The following is a description of a gene set: studied in species Homo sapiens An increased susceptibility to lower respiratory tract infections as manifested by a history of recurrent lower respiratory tract infections. Human Gene Set: HP_RECURRENT_LOWER_RESPIRATORY_TRACT_INFECTIONS Recurrent lower respiratory tract infections, and this is the list of marker genes: SLC19A1, SLC11A1, STIM1, EXTL3, IRF1, FCN3, HYOU1, MAP3K14, MALT1 (MALT1 paracaspase), PRKDC, TNFSF12, CYBC1, DOCK11, G6PC3, NCF2, SIAH1, COL6A1, NME5, NFE2L2, ZNF668, CTCF, FMO3, PKHD1, CD40LG, DNAAF4, TCF3, RFT1, COLQ, USP26, ZBTB7A, DNAJB13, CFAP410, SCNN1B, IL21R, TNFRSF13B, RFXANK, IFIH1, RPGR, C4B, RAC2, HMOX1, RAC1, IL6ST, SLC6A14, TAFAZZIN, CD27, RNF125 (NCBI Gene Id 54941), MRAP, BLNK, MDFIC (NCBI Gene Id 29969), ARHGEF1, NDUFC2, ODAD2, CLPB, SLC35C1, MASP2, GAS8, COL6A2, CD79A, NFKB1, DCLRE1C, NBN, FUT8, AP3B1, EFEMP2, CXCR4, TRIM37, LEP, STX1A, GNPTAB, KCNN4, DOCK8, LTBP1, CEACAM3, TK2, EDNRA, C1QB, GCLC, DNAI1, CLXN, IL2RG (NCBI Gene Id 3561), CEACAM6, ALMS1, FBLN5, GEMIN4, HYDIN, AGR2, SLC9A3, VARS1, ALB, PLOD1, OFD1, LCK, WDR35, DNAAF1, IL17RA, CD3E, EGFR, RFX5, ZAP70 (zeta chain of T cell receptor associated protein kinase 70), CD81, RFXAP, COL5A1, PNP, JAK3, CCDC39, POLE, RASGRP1, SATB1, ALG12, NFKB2, ATM (NCBI Gene Id 8068), ARPC1B, MGAT2, DDR2, TPP2, CD3D, ADA, GLI3, ODAD1, MIF, KCNJ6, MGP (NCBI Gene Id 4256), PYROXD1, VPS33A, SERPINA1, SREBF1 (sterol regulatory element binding transcription factor 1), TGFB1, ICOSLG (inducible T cell costimulator ligand), SCNN1A, CBLB, SFTPC (surfactant protein C), SEC61A1, USP9X, PGM3, SLC26A9, PIK3CD (phosphatidylinositol-4,5-bisphosphate 3-kinase catalytic subunit delta), TNFRSF11A, CAVIN1, STAT3, DPP9, POLD1, CD19, UNG, NKX2-1 (NK2 homeobox 1), CD79B, COL11A2 (collagen type XI alpha 2 chain), GORAB, SOX9, FBXW7, PRKCD, TNFRSF9 (NCBI Gene Id 3604), AASS, SETBP1, CIITA, USB1 (NCBI Gene Id 79650), LIG1, IGHM (NCBI Gene Id 3507), DIP2B, PURA, POLA1, IFT56, TONSL, DRC1, LRBA, SLC4A10, CYBA, ZNFX1, TBCD, WDR1, CR2, DAW1, IGBP1, POLD3, RELB, IGKC, CCDC40, CYBB, CARD10, LRRC56, LTBP4, MEGF10, CDKL5, PEPD (peptidase D), FOXJ1, WDR19, LAMA2 (laminin subunit alpha 2), CORO1A, DZIP1L, IL7R, CARMIL2, HFE, PIK3R1, TBX1, LMNB1, RAG1, FCGR2A, C3, ORC6, GSTM3, PTEN, MYSM1, CFTR, RNU4-2, IGLL1, NCF1 (NCBI Gene Id 653844), CD247, KPTN, ERCC6, IL10RB, STX3, MED25, SERPINH1, RNF168, IDS, COL13A1, MS4A1, PSMD12, IDH1, GALNS, TAP1, TNFRSF13C, LAMB2, B3GALT6, UNC119, WAS, ICOS, SASH3, P4HTM, SCNN1G, FCHO1, CD55 (NCBI Gene Id 1604), RFX7, RNU4ATAC, DCTN4, SMARCA2 (SWI/SNF related, matrix associated, actin dependent regulator of chromatin, subfamily a, member 2), MAGT1, ZNF341, BTK, MTHFD1, STK36, DNAH11, IRF2BP2, CLCA4, CTLA4, PKP1, AICDA, ODAD4, NUP214, SMARCD2, RAG2, STK4, DOCK2, LAT, CEBPE, IGHG2